Given this list of marker genes CPA1, ATP6V1E1, ATP6V1C1, ATP6V1B2, CPA2, CPB1, ATP6V1F, AEBP1, CTSA, CPB2, CPN1, CPM, here is a description of the gene set: Human Gene Set: MODULE_402 studied in species Homo sapiens Genes in the cancer module 402.